The following is a description of a gene set: species: Homo sapiens Genes positively correlated with age in peripheral blood mononuclear cell in adults (18-64) after exposure to Pandemrix, time point 1D Adjuvanted vaccines afford invaluable protection against disease, and the molecular and cellular changes they induce offer direct insight into human immunobiology. Here we show that within 24 h of receiving adjuvanted swine flu vaccine, healthy individuals made expansive, complex molecular and cellular responses that included overt lymphoid as well as myeloid contributions. Unexpectedly, this early response was subtly but significantly different in people older than ~35 years. Wide-ranging adverse clinical events can seriously confound vaccine adoption, but whether there are immunological correlates of these is unknown. Here we identify a molecular signature of adverse events that was commonly associated with an existing B cell phenotype. Thus immunophenotypic variation among healthy humans may be manifest in complex pathophysiological responses. Human Gene Set: SOBOLEV_PBMC_PANDEMRIX_AGE_18_64YO_CORRELATED_WITH_AGE_1DY_POSITIVE from publication Sobolev O, Binda E, O'Farrell S, Lorenc A, Pradines J, Huang Y, Duffner J, Schulz R, Cason J, Zambon M, Malim MH, Peakman M, Cope A, Capila I, Kaundinya GV, Hayday AC (PMID 26726811), and this is the list of marker genes: CD28, PYCR1, HDAC4, LIM2, OPTN, SYNM, DOCK4, CACNA1I, TNFRSF1A, FGFBP2, LPAR1 (NCBI Gene Id 1902), MXI1, KIF21B, PRSS23, C1D, ENO2, SYNE1, EEF2 (eukaryotic translation elongation factor 2), AK1, CD38, ENSG00000293341, IL11RA, VPS37A, CARD16 (NCBI Gene Id 114769), IGFBP3, NETO2, TBX21, NLRP1 (NCBI Gene Id 82286), MCOLN2, CACNA2D2